Given this list of marker genes LRP4, AK9, MUSK, SCN4A, CHRND (NCBI Gene Id 1144), GFPT1, CHRNA1, DOK7, AGRN, RAPSN, COLQ, LAMB2, CHRNB1, CHRNE, COL13A1, here is a description of the gene set: Decreased size of nerve terminals Human Gene Set: HP_DECREASED_SIZE_OF_NERVE_TERMINALS A reduction in the size of nerve terminals. studied in species Homo sapiens